The following is a description of a gene set: Genes up-regulated in dendritic cells stimulated by LPS: wildtype versus KDM4D. from publication Zhu Y, van Essen D, Saccani S (PMID 22633489) Human Gene Set: GSE32255_WT_VS_JMJD2D_KNOCKDOWN_4H_LPS_STIM_DC_UP In dendritic cells, expression of the H3K9me3 demethylase JmjD2d is upregulated by LPS stimulation. To identify genes whose induction by LPS depends on JmjD2d activity, we performed a microarray analysis of wild-type and JmjD2d-knockdown dendritic cells, before and after stimulation with LPS. studied in species Homo sapiens, and this is the list of marker genes: RGS11, SLC16A10 (solute carrier family 16 member 10), NFAM1, AHDC1, NUDT11, AMPD1, SMAD5, UNC79, PRF1, SYNM, MAP4K4, RANBP10, TRPC2, ESAM, PAFAH2, PAQR7, RAB3IP, POLR3E, SLC35F3, TATDN2, SH3PXD2A, LRATD2, MAML3, ETS2, SLC20A1, TPSB2, MFSD6, SNORA30, BDH1, TENT5A, DAPK1, DCUN1D1, RINT1, CLIP1, KLHDC1, CD300C, GALNT7, CD40LG, PTPN6 (NCBI Gene Id 5777), CEP68, RNF145, PDE7A, DNAJB3, RNF19A, MESP2, KHDRBS3, TRAPPC2L, TECPR1, DYRK2, SINHCAF, PAG1, PIK3R5, ITPR3, ATP1B1 (NCBI Gene Id 481), PADI2 (peptidyl arginine deiminase 2), DGKD, GTF2I, SLC30A4 (solute carrier family 30 member 4), SCML4, FHIP1B, GALNT4, ZNRF2, CELF1, SGMS1 (sphingomyelin synthase 1), PDLIM1, RAB9A, FCGRT, ICAM2, SDK2, RAB33A, KREMEN1, ARHGAP29, SLC26A11, EXOG, DNAAF5, TXK, PIGV, PRKCB, TAF4, PROM2, ADCY6, GSN, NRAS, ST8SIA1, CDR2, NDUFS5, PFKFB4, ACVRL1, UBQLN2, ITM2A, POLR1A, EGFLAM, CIMIP2B, TECPR2, CSRNP2, RFLNB, VIPR1, RTN4RL1, RAMP1, ADH1A, BCL9L, ETV3, GIGYF2, TANC1, DNAJC6, HOGA1, ADGRG3, GCN1, TREML2, MCTP2, TMIE, FBXO21, DAPL1, AFG2B, CHD7, GPR18, EYA2, FILIP1L, SLFN5, SMARCA2, PPIC, GPR183, PRPF40B, LRRC23, ADAMTS14, UBE2E2, MYO9B, IGFBP4, RGMB, WASL, IARS1, ALS2CL, RFFL, CXCR1, EME2, PPEF1, APP, CNN3, PDLIM4 (PDZ and LIM domain 4), MIR99A (NCBI Gene Id 407055), GPR132, H2BC21, UOX, GPR171, HEATR5A, CRIPTO, C19orf38, DGAT2L6, SLC5A12 (NCBI Gene Id 159963), PDK1, PDLIM5, PATZ1, CDH24, ACIN1, PLCL2